The following is a description of a gene set: studied in species Homo sapiens Any process that results in a change in state or activity of a cell or an organism (in terms of movement, secretion, enzyme production, gene expression, etc.) as a result of a fatty acid stimulus. Human Gene Set: GOBP_RESPONSE_TO_FATTY_ACID, and this is the list of marker genes: ACSL1, GLDC, GIPR, CAV3, HES1, CD36, PRKCD, OR51E2, FOXO1, PIK3CA, FFAR1, CREB1, SREBF1 (NCBI Gene Id 6720), CCNB1, AKR1C1, HMGCS2, PID1, PDK3, INSIG2, CPT1A, PPP5C, ID3, SCD, NR1H4, FFAR3, CPS1, SMARCD1, CDK4, AKR1C3, CLDN1, TBXAS1, ILDR1, AKR1C4, AKR1C2, PLCB1, FFAR2, IRS1 (insulin receptor substrate 1), LDLR, KCNK2, EDN1, PDX1, LPL, ALAD, KCNK4, UCP1, CD4, KCNK10 (NCBI Gene Id 54430), JUND, BOLA3, DGAT2, ZNF683, MIR92A1, ADIPOQ, ZC3H12A, PDK4, FOXO3, UCP2, E2F1, SOX9, FABP3, CAT, ASS1